Given this list of marker genes PUM3, BANF1, SPINDOC, HPF1, MARCHF6-DT, XRCC1, here is a description of the gene set: Human Gene Set: GOBP_REGULATION_OF_PROTEIN_ADP_RIBOSYLATION Any process that modulates the frequency, rate or extent of protein ADP-ribosylation. Protein ADP-ribosylation is the transfer, from NAD, of ADP-ribose to protein amino acids. studied in species Homo sapiens